The following is a description of a gene set: Chromatin that is part of a sex chromosome. Human Gene Set: GOCC_SEX_CHROMATIN studied in species Homo sapiens, and this is the list of marker genes: PHC1, RNF2, EED, RING1, SUZ12, PCGF2, MACROH2A1